The following is a description of a gene set: Expression microarray analysis identified over genes regulated during puberty in the mouse mammary gland. Most prominent were genes whose expression increased in parallel with pubertal development and remained high thereafter. Members of the Wnt, transforming growth factor-beta and oestrogen-signalling pathways were significantly overrepresented. Comparison to expression data from CITED1 knockout mice identified a subset of oestrogen-responsive genes displaying altered expression in the absence of CITED1. Included in this subset are stanniocalcin2 (Stc2) and amphiregulin (Areg). Chromatin immunoprecipitation revealed that ERalpha binds to oestrogen response elements in both the Stc2 and Areg genes in the mammary gland during puberty. Additionally, CITED1 and ERalpha localize to the same epithelial cells of the pubertal mammary gland, supporting a role for interaction of these two proteins during normal development. In a human breast cancer data set, expression of Stc2, Areg and CITED1 parallel that of ERalpha. Similar to ERalpha, CITED1 expression correlates with good outcome in breast cancer, implying that potential maintenance of the ERalpha-CITED1 co-regulated signalling pathway in breast tumours can indicate good prognosis. Pubertal genes down-regulated by TGFB1. from publication McBryan J, Howlin J, Kenny PA, Shioda T, Martin F (PMID 17486082) studied in species Mus musculus Mouse Gene Set: MCBRYAN_PUBERTAL_TGFB1_TARGETS_DN, and this is the list of marker genes: Chi3l1, Gzma, Rbbp4, Pfn2, Ptn, Idh1, Nid2, Plpp2, Spint2, Nid1, Sftpd, Aldh1a1, Arhgef3, Sfrp1, Cdh5, Cdh1, Slc12a2, Mt2, Gsta3, Tcf7, Lcn2, Gata3, Dapk1, Slpi (NCBI Gene Id 20568), Ppp1r3c, Vwf, Id4, Rab27b, Pttg1, Apod, Klf5, Ifit3, Ptgis, Ptx3, Cldn4, Cd9, Areg, Hspa1b, Csn3, Ednra, Rbm5, Nfkb2, Tnfaip2, Abcc3, Bcl6, Apoc2, Adm, Bcl3, Lrp5, Nherf1, Phlda1, Kitl, Sod2, Jchain, Pdk4 (pyruvate dehydrogenase kinase, isoenzyme 4), Rgs2 (NCBI Gene Id 19735), Vapb, Gclc, Tyr, Id2, Erbb3, Sftpb, Mbtps1